The following is a description of a gene set: Any process that results in a change in state or activity of a cell (in terms of movement, secretion, enzyme production, gene expression, etc.) as a result of a peptide stimulus. studied in species Mus musculus Mouse Gene Set: GOBP_CELLULAR_RESPONSE_TO_PEPTIDE, and this is the list of marker genes: Ppp1r9b, Timp1, Klf3, Ano1, Fis1, Irs2, Klf5, Klf11, Smpd3, Klf2, Klf15, Casr, Npr2, Nfkb1, Akt1, Klf4